Given this list of marker genes PSMA6, UBA52, PSMC5, UBB, CUL1, PSMB1, UBC, PSMC1, PSMD1, PSMD13, PSMB6, PSMB2, RPS27A, PSMD11, PSMC2, BTRC, PSMB3, PSMC3, ADRM1, FBXO5, PSMD14, PSMB7 (NCBI Gene Id 5695), PSMA3, PSMA5, PSMC4, PSMA1, PSMD3, PSMD8, FZR1 (NCBI Gene Id 8855), PSMD7, CDC20, PSMA4, SKP1, PSMA7, PSMB4, SEM1, PSMA2, PSMC6, PSMD2, PSMD6, PSMB5, PSMD12, here is a description of the gene set: species: Homo sapiens part of: Regulation of APC/C activators between G1/S and early anaphase Reactome Pathway: SCF-beta-TrCP mediated degradation of Emi1 Emi1 destruction in early mitosis requires the SCF beta-TrCP ubiquitin ligase complex. Binding of beta-TrCP to Emi1 occurs in late prophase and requires phosphorylation at the DSGxxS consensus motif as well as Cdk mediated phosphorylation. A two-step mechanism has been proposed in which the phosphorylation of Emi1 by Cdc2 occurs after the G2-M transition followed soon after by binding of beta-TrCP to the DSGxxS phosphorylation sites. Emi1 is then poly-ubiquitinated and degraded by the 26S proteasome.